Given this list of marker genes IFITM3, IFIT3, GBP1, RSAD2, OASL (NCBI Gene Id 8638), IFIT1, OAS2, OAS1, GBP5, here is a description of the gene set: from publication Cao RG, Suarez NM, Obermoser G, Lopez SM, Flano E, Mertz SE, Albrecht RA, García-Sastre A, Mejias A, Xu H, Qin H, Blankenship D, Palucka K, Pascual V, Ramilo O (PMID 24495909) Human Gene Set: CAO_BLOOD_FLUMIST_AGE_05_14YO_CORRELATED_WITH_H3N2_VN_TITER_7DY_POSITIVE Genes positively correlated with H3N2 VN titer in blood in children (0.5-14y) after exposure to FluMist, time point 7D. Comment: ~80% of cohort were white, ~50/50 Female:male BACKGROUND: Live attenuated influenza vaccine (LAIV) and trivalent inactivated influenza vaccine (TIV) are effective for prevention of influenza virus infection in children, but the mechanisms associated with protection are not well defined. METHODS: We analyzed the differences in B-cell responses and transcriptional profiles in children aged 6 months to 14 years immunized with these 2 vaccines. RESULTS: LAIV elicited a significant increase in naive, memory, and transitional B cells on day 30 after vaccination, whereas TIV elicited an increased number of plasmablasts on day 7. Antibody titers against the 3 vaccine strains (H1N1, H3N2, and B) were significantly higher in the TIV group and correlated with number of antibody-secreting cells. Both vaccines induced overexpression of interferon (IFN)-signaling genes but with different kinetics. TIV induced expression of IFN genes on day 1 after vaccination in all age groups, and LAIV induced expression of IFN genes on day 7 after vaccination but only in children < 5 years old. IFN-related genes overexpressed in both vaccinated groups correlated with H3N2 antibody titers. CONCLUSIONS: These results suggest that LAIV and TIV induced significantly different B-cell responses in vaccinated children. Early induction of IFN appears to be important for development of antibody responses. studied in species Homo sapiens